Given this list of marker genes MIR764, MFN1P1, SSU72P1, HMGB1P12, FCF1P4, HTR2C, DPRXP7, XACT, QTRT1P1, RBMXL3, CAPN6, CHRDL1, MIR448, LUZP4, ACSL4, RNU6-154P, AKR1B1P8, MIR3978, TMEM164, RNU6-1015P, SLC6A14P1, MIR1911, PLS3-AS1, ALG13, TNPO3P1, IL13RA2, TRPC5OS, TUBAP6, AMMECR1, RN7SL93P, TCERG1P1, HMGB3P30 (NCBI Gene Id 203510), SNORA35B, CT83, PPIHP2, AMMECR1-IT1 (AMMECR1 intronic transcript 1), TRPC5, SETP8 (NCBI Gene Id 100128536), SNORA35, RTL9, SNORD96B, DCX, RN7SL712P, RNA5SP512, YAP1P2, PRPF4BP1, CRIPTO3 (NCBI Gene Id 6998), GNG5B, EIF4BP7, MIR1264, AMOT, RTL4, NXT2, SLC6A14P2, EEF1GP5 (NCBI Gene Id 648407), HSPA8P7, KCNE5, API5P1, RPL36P18 (NCBI Gene Id 100271394), MIR1298, SLC6A14, ASS1P5 (NCBI Gene Id 450), RPS5P7, MIR1912, MIR4329, M6PRP1, SUMO2P21, GUCY2F, PAK3, RNU6-648P, RPL18AP15, LHFPL1, SERTM2, MIR652, DANT1, RPL36AP53, RNU1-57P, PLS3, LRCH2, DANT2, RNU6-1323P, PHF5AP4, RNU6-496P, GLUD1P9, ALG13-AS1, CCDC121P1, RN7SL266P, AGTR2, here is a description of the gene set: Human Gene Set: chrXq23 species: Homo sapiens